Given this list of marker genes SLC5A6, PAGE4, ONECUT2, TMEM150C, LGR5, SLC16A11, ASPSCR1, PXYLP1, ACOX1, TRPM7, MLXIPL, SLC6A8, CKB, ADM, RHBG, TRIB2, TENM2, C3orf85, DAAM1, ZNF385B, NR2F1, HLF, KANSL1, ESM1, TNFRSF19, TAPT1-AS1, FADS1, ZNRF3 (zinc and ring finger 3), FAM169A, HSDL2, VWCE, SLC16A10, MOGAT1, ZNF703, DNM1, PRAG1 (NCBI Gene Id 157285), GABPB2, EXPH5, ATP6V0E2, CDC14B, IGF2, GRB10, NEK3, USP54, MME, CCDC170, AMACR, BTNL9, SLC13A3, NKD1, CRLS1, PHYHIPL (phytanoyl-CoA 2-hydroxylase interacting protein like), here is a description of the gene set: studied in species Homo sapiens from publication Chiang DY, Villanueva A, Hoshida Y, Peix J, Newell P, Minguez B, LeBlanc AC, Donovan DJ, Thung SN, Solé M, Tovar V, Alsinet C, Ramos AH, Barretina J, Roayaie S, Schwartz M, Waxman S, Bruix J, Mazzaferro V, Ligon AH, Najfeld V, Friedman SL, Sellers WR, Meyerson M, Llovet JM (PMID 18701503) All marker genes down-regulated in the 'interferon' subclass of hepatocellular carcinoma (HCC). Human Gene Set: CHIANG_LIVER_CANCER_SUBCLASS_INTERFERON_DN Hepatocellular carcinomas represent the third leading cause of cancer-related deaths worldwide. The vast majority of cases arise in the context of chronic liver injury due to hepatitis B virus or hepatitis C virus infection. To identify genetic mechanisms of hepatocarcinogenesis, we characterized copy number alterations and gene expression profiles from the same set of tumors associated with hepatitis C virus. Most tumors harbored 1q gain, 8q gain, or 8p loss, with occasional alterations in 13 additional chromosome arms. In addition to amplifications at 11q13 in 6 of 103 tumors, 4 tumors harbored focal gains at 6p21 incorporating vascular endothelial growth factor A (VEGFA). Fluorescence in situ hybridization on an independent validation set of 210 tumors found 6p21 high-level gains in 14 tumors, as well as 2 tumors with 6p21 amplifications. Strikingly, this locus overlapped with copy gains in 4 of 371 lung adenocarcinomas. Overexpression of VEGFA via 6p21 gain in hepatocellular carcinomas suggested a novel, non-cell-autonomous mechanism of oncogene activation. Hierarchical clustering of gene expression among 91 of these tumors identified five classes, including CTNNB1, proliferation, IFN-related, a novel class defined by polysomy of chromosome 7, and an unannotated class. These class labels were further supported by molecular data; mutations in CTNNB1 were enriched in the CTNNB1 class, whereas insulin-like growth factor I receptor and RPS6 phosphorylation were enriched in the proliferation class. The enrichment of signaling pathway alterations in gene expression classes provides insights on hepatocellular carcinoma pathogenesis. Furthermore, the prevalence of VEGFA high-level gains in multiple tumor types suggests indications for clinical trials of antiangiogenic therapies.